Given this list of marker genes MYH7, RAD52, MAT1A, BEST1 (bestrophin 1), SPPL2B, ATF3, UBE2D2, DCAF1, ASXL2, ACADVL, ST8SIA4, ROS1, EIF2B3, THSD4, CIITA, TSR3, TBL1XR1, MAPK8 (mitogen-activated protein kinase 8), SLC4A3, FRAT1, FAM13B, TRPC2, DUSP1, ANKS1A, ATG13, AGO1, RASSF1, NKX2-1, SACM1L, RIMS1, PLCB3 (NCBI Gene Id 5331), LST1, CTPS2, SCNM1, CREBL2, HSPBAP1, CSF3R, PRKCI, SS18L1, RETREG2, TBRG4, USP24, ST7, INPP5J, GNAI3, LRP5L, ASPA, RUVBL2, IFRD1, TUBB4B, HCFC1R1, RMDN1, KLF12, PKD2, CITED2, MTG1, KCNIP1, AHR, SCRIB, SEC24A, MT1HL1, SAP30, TACR3, CASZ1, TCF20, HILPDA, EIF3D, ADO, GUSBP11, FAM136A, PRPF38B, GSK3B, F7, CYP4F2, PITPNM1, LILRB4, MYH1, DEPP1, COQ6, TSC1, CYB5R3 (cytochrome b5 reductase 3), EIF3H, TCP1, QRICH1, SEMG1, CHRNA5, FABP6, SRSF7, NXPE3, MARCHF1, HSD3B1, MT1F, IER5, IRAK1, STX17, DCAKD, C6orf120, TARBP1 (NCBI Gene Id 6894), TOX, DGKA, IFNA16 (NCBI Gene Id 3449), VPS37C, EIF4G3, PLPP1, ZNF225, TUBB3, SKIC3, PLXNA1, KLF6, ZFP36L2, LARS2, ALPG, ITGB1BP1, FAM216A, GRAMD4, IQSEC1, SSBP1, MACF1, NAT9, GPR107, CSH2, KPNA3, LDHA, HERC1, PDE5A, ATP8B4, TRIM48, JUN, CD14, EMCN, UFL1, BCKDK, FNTA, SYMPK, C10orf88, DARS2, ADAP1, SNHG3, TMEM43, NFE2L3 (NCBI Gene Id 9603), GNL1, CRIP2, EFNA4, PNP, ALDH9A1, ENY2, BICRAL, DOK2, FKBP3, KCNQ1 (potassium voltage-gated channel subfamily Q member 1), EGR1, IDI2-AS1, CEL, SAP30L-AS1, EPS15, LY86, NACC2, SP4, IFNB1, N4BP1, CHRNE, GRK2, NRDC, FAM184A, KRT32, KCTD12, IRF9, POLG, AMD1, ZNF557, TGOLN2, GLG1, RGS10, ZNF613, EXOSC5, ECH1, CKLF, SUN1, ZNF250, TRNAU1AP, NOTCH2, GOLT1B, AGR2, LEMD3, FBXO42, MPDU1, ZBP1, RPL27, RHOBTB2, PIGP, PPP1R10, EIF4G2, CMPK1, DEXI, DVL2 (dishevelled segment polarity protein 2), KRT1, OBSL1 (obscurin like cytoskeletal adaptor 1), PDCD6, here is a description of the gene set: from publication Nakaya HI, Wrammert J, Lee EK, Racioppi L, Marie-Kunze S, Haining WN, Means AR, Kasturi SP, Khan N, Li GM, McCausland M, Kanchan V, Kokko KE, Li S, Elbein R, Mehta AK, Aderem A, Subbarao K, Ahmed R, Pulendran B (PMID 21743478) studied in species Homo sapiens Human Gene Set: GSE29618_PRE_VS_DAY7_FLU_VACCINE_MDC_DN Genes down-regulated in comparison of plasmacytoid dendritic cells (DC) from influenza vaccinee at day 0 versus myeloid DCs at day 7 post-vaccination. Systems vaccinology has emerged as an interdisciplinary field that combines systems wide measurements and network and predictive modeling applied to vaccinology. Here we used the systems vaccinology approach to study the molecular mechanisms underlying th